Given this list of marker genes TRAF4, SDC1, CEP44, CD40LG, EIF2B4, TNPO3, NSD3, ARHGAP8, IFT43, SET, RAB10, BCL6, ARF3, CPSF7, GEN1, HNRNPR, TCEA2, LIN28A, LRP5, JAK3, APBA1, FBXO8, PARN, GREM1, CISH (NCBI Gene Id 29917), SCAMP3, ASXL1, LIX1, TXN2, STX12, SNCB, IFTAP, POLR2M, ARPC1A, TNIP2, DRC7, CCDC85B, SEC14L2, SMC6, PCDH1, CEP164 (NCBI Gene Id 22897), TMEM95 (transmembrane protein 95), GABPB2, GABRA1, TDG, SSBP4, GSK3A, ZNF446, TPI1P2, SLC38A5, SDHAF2, BRD2, UBR1, GOLT1B, PASK, BTBD1, TCEAL1, ZFPM1, PPP1R7, SERPING1, ZNF235, PTHLH, SLC6A14, ANKS1A, WNT10A, CREBRF, MUC1, VPS53, RELA, here is a description of the gene set: studied in species Homo sapiens Human Gene Set: STAT1_01 Genes having at least one occurrence of the motif NNNSANTTCCGGGAANTGNSN in the regions spanning 4 kb centered on their transcription starting sites. This matches the STAT1 transcription factor binding site V$STAT1_01 (v7.4 TRANSFAC).